The following is a description of a gene set: species: Homo sapiens Abnormal uvea morphology An abnormality of the uvea, the vascular layer of the eyeball. Human Gene Set: HP_ABNORMAL_UVEA_MORPHOLOGY, and this is the list of marker genes: TEAD1, IDS, WHRN, POLR1D, CCM2, COL9A1, PTCH1, PRSS56, EFEMP1, DLL1, ZEB1, RFC2, LCA5, PDPN, BDNF, IFT74, ZIC2, LAMB2, SEM1, PAX6, HCCS, MMP23B, WAC, AKT1, WASHC5, TENM3, PAH, IL10, IKBKG, CDH3, BRIP1, UBE3A, ZNF668, PRPH2, TOGARAM1, WNT10B, NLRP1, COL8A2, IRF4, RAD51, KIFBP, MDH2, TFAP2A, CEP41, GABRD, KIF21A, BLOC1S3, MLPH, LARGE1, PIGL (phosphatidylinositol glycan anchor biosynthesis class L), SLC25A11, PEX19, TNFAIP3, UBE2T, KRAS, C12orf57, LDHD, CASZ1, NRL, INPP5E, STX1A, SEMA3E, FGFR1, EPS15L1, EPHA2, TKT, FGFRL1, AP1S3 (NCBI Gene Id 130340), LTBP2, NRAS, POGZ, MTSS2, CPLX1, PEX2, ESPN, ROBO1, MBTPS2, IGF1R, POLR1C, TGFBR2 (NCBI Gene Id 7048), PNPLA6, SMCHD1, FGF8, BUD23, IL6, SHH, GTF2I, EDN3, FANCB, STUB1, METTL27 (NCBI Gene Id 155368), C4A, PRKG1, CPLANE1, DLX6, PEX26, CHRDL1, LACC1, FGFR2, RSPO2, POMGNT2, MAX, COL3A1, PRKCZ, RLIM, FANCE, CBY1, MYO7A, OTX2, MICOS13, IL12A, MC1R, ANK1, GFAP, DLX5, HPS5, PALB2, ACTB, B3GALNT2, ERCC1, GMPPB, CHD7, ESAM, KRT71, FOXP1, NAA10, GJA1, RAB27A, GPR35, FOXE3, FOXH1, MAT2A, LOXL1 (lysyl oxidase like 1), POMT1, MFAP5, LRMDA, ALG3, PEX10, TBR1, LRBA, CLEC3B, ELOVL4, KCNAB2, VSX2, XIAP, LYST, NDE1, CRYGD, MITF, SMAD4, TUBGCP4, NR4A2, RLBP1, THSD4, SH3TC2, TMEM107, MED12L, DLST, BCL10, RAP1B, KRIT1, SPATA7, PEX6, BMP4, MPDZ, IMPG1, TMEM138, FGF3, VPS37D, PTPN11, TRIM44, IFNG, TGFBR1, SALL2, ARMC9, MYH11, TMEM67, PITX2, FBN1, SDHA, ATP6V1A, ABCB6, CHN1, SALL4, COL4A1, GDF3, SDHC, COX7B, ATOH7, TCEAL1, MIR184, ITPR1, SPRED1, BRCA2, TUBA1A, C1QTNF5, HEY2, HS2ST1, TCOF1, FANCC, HRAS, TRIM28, MAB21L2, MMP14 (NCBI Gene Id 4323), SPRED2 (sprouty related EVH1 domain containing 2), BLM, WDR73, ADAMTSL4, DDX6, ANKRD55, LOX, ALX3, IL23R, TGFB3, ERCC4, FOXC1, FH, VHL, EIF4H, CRYAA, NLRP3, TYRP1, UBAC2 (UBA domain containing 2), ACTA2, SUFU, CBL, CYSLTR2, ELP1, LRAT (NCBI Gene Id 9227), FBXW4, HLA-B, TGFB2, POLR1B, ZNF408, MKS1, CENPF, NDP, SDHAF2, FLI1, NOTCH3, TP63, CCDC22, LPAR6, PORCN, TGIF1, GPC3, PEX1, CRX, CDH23, VSX1 (visual system homeobox 1), NPHP1, BEST1, CLCNKB, DNAJC30, B4GAT1, PEX14, CLCN2, SIM1, CRYBB1, ERAP1, VWA8, CEP290, CRPPA (NCBI Gene Id 730683), KITLG, DNASE1L3, TBX2, TUBB2B (tubulin beta 2B class IIb), CCR1, OFD1, KIAA0586, FASLG, PRDM16, TMEM231, NOD2, GTF2IRD2, VPS33A, ROM1, TRPM3, VPS13B, KATNIP, MFRP (membrane frizzled-related protein), FLNA, TEK, GNAQ (NCBI Gene Id 2776), DYRK1A, ENPP1, DACT1, SOX2 (SRY-box transcription factor 2), PRR12, GUCA1A, PAX3, BRCA1, SEMA4D, PEX12 (peroxisomal biogenesis factor 12), RP2, SKI, ERCC8, DPYSL5, TCTN3, JAG1, CSPP1, SNAI2, IL2RB, RASA2, UBE4B, COQ2, TXNDC15, PCDH15, CEP78, APOE, EDNRB (endothelin receptor type B), NODAL, RHOA, CYP4V2, CRYGC, ZNF423, PIK3R1, PTPN2, KIT, PAX2, AIRE, TMEM237 (transmembrane protein 237), H19, PEX16, TYR, BTNL2, FANCG, CFI, RPGRIP1, FKRP, PUF60, XYLT1, ACVRL1, TIMP3, CDON, NF1, EDC3, SAG, POMT2, CLRN1, AGXT, AP3B1, HMX1, SIX3, SDHD, FANCM, FAS, BAZ1B, NCF1, LRP5, KIF11, FANCI (FA complementation group I), NDN, OCRL, FZD5 (NCBI Gene Id 81561), MALT1, TCTN1, HPS6, USH2A, GUCY2D, PCYT1A, TMEM216, DISP1, DIS3L2, CC2D2A, B9D2, RRAS2, CASP10, REST, OCA2, LIMK1, GMPPA, HPS4, RPGRIP1L, RBP4, RNU7-1, GAS1, POU3F4, TUBGCP6, YAP1, HYLS1 (NCBI Gene Id 50957), SLX4, CTNNB1, B3GLCT, GRHL2, PTEN, TMEM98, DPP6, HPS1, ARSG, TBX22, TINF2, ADAMTSL1, RERE, COL25A1, MYO5A, CYP1B1, FBN2, AP3D1 (NCBI Gene Id 8943), FANCL, PEX11B, ALG2, MT-TS2, AHI1, PIBF1, IMPG2, SRD5A3, HLA-DRB1, HMCN1, PDE6D, DHX16, CNGB3, HMGB3, LIPH (lipase H), MIF, SIX6, BAP1, SDHB, SLC45A2, HARS1, SPTBN1, IFNGR1, PTCH2 (NCBI Gene Id 8643), LMX1B, PDZD7, EYS, SMO, RB1, TRIP13, FKTN, SPEN, SIN3A, FANCD2, LRP2, ABCC6, CRYBB2, SMAD2, BLOC1S5, CEP120, TSC2, TMEM270, SNRPN, FBLN5, KIF1B, TBL2, KLRC4, LZTR1, PEX13, OAT, GNA11, FANCF, ELP4, FZD4, SALL1, TLR4, BTRC, CRB1, BLOC1S6, MST1, CD27, USH1G, MYOC, POMK, B9D1, MAD2L2, CIB2, MAPK1, SF3B1, TMEM218, SOS2, ATP10A, TNFRSF1A, WT1, IL36RN, ARL3, FKBP6, TCF4, HLA-A, PRKAR1A, CLDN19, XYLT2, RFWD3, IL12A-AS1, TSPAN12, ADAMTS18, RXYLT1, CEP104, RIT1, MIR204 (NCBI Gene Id 406987), FSCN2, DHCR7, IGBP1, LETM1, TRIM37, AAAS, TCTN2, ARL6IP6 (ADP ribosylation factor like GTPase 6 interacting protein 6), PTPN22, PIGG, XRCC2, BIRC3, PXDN (peroxidasin), RRAS, MEFV (NCBI Gene Id 4210), ERF, DCT, CPAMD8, FAM111A, MSH6, IL2RA, ACTG1, UBE3B, ABCA4, STAT4, BCOR, GTF2IRD1, ALDH1A3, MRAS, GLI2, TBX4, MAPKAPK3, HHAT, CFHR1, KCTD1, PMP22, SOS1, TMEM127, LUZP1, ASPH, TONSL, SOX10, USH1C, SLC24A5, PIK3CA (phosphatidylinositol-4,5-bisphosphate 3-kinase catalytic subunit alpha), NF2, CTBP1, MPZ, RAX, MLXIPL, POU6F2, MAGEL2, FANCA, PDE4D, TSC1, ADNP, VPS35L, KANSL1, SLC25A15, PEX5, GZF1, COL18A1, ARL13B, ROR1, POMGNT1, CHM, FBLN1, MAF, CRIPTO, CFH, NELFA, NDUFB11, NOTCH2, ELN (NCBI Gene Id 2006), NSD2, DAG1, KRT74, MAFB, ADAMTS17, PEX3, LIG4, CAPN5, KMT2D, CD247, RET, HSPG2, CFHR3, MYLK, CLIP2, STIM1, HERC2, OVOL2, NSUN2, ADGRV1, ERCC6, WNT3, HADHA, PDCD10, CHD6, DTNBP1, KIAA0753, SMAD3, PROM1, MMP2, ZEB2, TUBB3, GPR143, GJA8, PHOX2A, RPE65, PHOX2B, CRYBA4, RAD51C, EPG5, WDR45, KRT25, RAF1, VCAN (NCBI Gene Id 7902)